Given this list of marker genes ABHD1, ABHD2, ACADM, ABHD3, GLYATL2, here is a description of the gene set: Human Gene Set: GOBP_MEDIUM_CHAIN_FATTY_ACID_CATABOLIC_PROCESS The chemical reactions and pathways resulting in the breakdown of a medium-chain fatty acid. A medium-chain fatty acid has an aliphatic tail containing 6 to 12 carbons. species: Homo sapiens